Given this list of marker genes STEAP3, ATP6AP1, TFRC, TFR2, ATP6V1F, ATP6V0C, ATP6V1C1, STEAP4, ATP6V0B, ATP6V0D2 (NCBI Gene Id 245972), ATP6V1D, MCOLN1, ATP6V1A, ATP6V1G3, ATP6V0E1, ATP6V1B1, ATP6V1C2, TCIRG1 (T cell immune regulator 1, ATPase H+ transporting V0 subunit a3), HFE, ATP6V1E2, ATP6V0D1, ATP6V1H, ATP6V1G2, ATP6V0E2, ATP6V0A2, ATP6V0A4, ATP6V0A1, ATP6V1G1, ATP6V1B2, ATP6V1E1, TF, here is a description of the gene set: part of: Iron uptake and transport studied in species Homo sapiens Reactome Pathway: Transferrin endocytosis and recycling Endocytosis of iron loaded transferrin/receptor complex leads, after acidification of the endosome, to the separation of iron and its diffusion out of the vesicle. The endosome is not fused with a lysosome but recycles its content back to the cell surface where soon transferrin dissociates from its receptor.